Given this list of marker genes Apln, Htr2a, Tnfsf11, Ednrb (NCBI Gene Id 13618), Cnr1, Arrdc3, Il1b, Ptges, Ptger3, Ptgs2, Nmu, Tnfrsf11a, Abat, Ccl5, Ccr5, Tnf, Slc27a1, here is a description of the gene set: species: Mus musculus Mouse Gene Set: GOBP_REGULATION_OF_HEAT_GENERATION Any process that modulates the rate or extent of heat generation.